The following is a description of a gene set: studied in species Mus musculus Mouse Gene Set: GOCC_EUKARYOTIC_TRANSLATION_INITIATION_FACTOR_3_COMPLEX A complex of several polypeptides that plays at least two important roles in protein synthesis: First, eIF3 binds to the 40S ribosome and facilitates loading of the Met-tRNA/eIF2.GTP ternary complex to form the 43S preinitiation complex. Subsequently, eIF3 apparently assists eIF4 in recruiting mRNAs to the 43S complex. The eIF3 complex contains five conserved core subunits, and may contain several additional proteins; the non-core subunits are thought to mediate association of the complex with specific sets of mRNAs., and this is the list of marker genes: Eif3f (eukaryotic translation initiation factor 3, subunit F), Eif3m, Eif3h, D1Pas1, Eif3i, Eif3d, Ddx3x, Eif3k, Eif3a, Eif3e, Eif3j2, Eif3c, Eif3g, Eif3j1, Eif3l, Eif3b